The following is a description of a gene set: The dendritic cell (DC) is a master regulator of immune responses. Pathogenic viruses subvert normal immune function in DCs through the expression of immune antagonists. Understanding how these antagonists interact with the host immune system requires knowledge of the underlying genetic regulatory network that operates during an uninhibited antiviral response. In order to isolate and identify this network, we studied DCs infected with Newcastle Disease Virus (NDV), which is able to stimulate innate immunity and DC maturation through activation of RIG-I signaling, but lacks the ability to evade the human interferon response. To analyze this experimental model, we developed a new approach integrating genome-wide expression kinetics and time-dependent promoter analysis. We found that the genetic program underlying the antiviral cell state transition during the first 18-hours post-infection could be explained by a single regulatory network. Gene expression changes were driven by a step-wise multi-factor cascading control mechanism, where the specific transcription factors controlling expression changed over time. Within this network, most individual genes are regulated by multiple factors, indicating robustness against virus-encoded immune evasion genes. In addition to effectively recapitulating current biological knowledge, we predicted, and validated experimentally, antiviral roles for several novel transcription factors. More generally, our results show how a genetic program can be temporally controlled through a single regulatory network to achieve the large-scale genetic reprogramming characteristic of cell state transitions. Genes down-regulated in comparison of control conventional dendritic cells (cDC) at 0 h versus cDCs infected with Newcastle disease virus (NDV) at 10 h. Human Gene Set: GSE18791_CTRL_VS_NEWCASTLE_VIRUS_DC_10H_DN studied in species Homo sapiens from publication Zaslavsky E, Hershberg U, Seto J, Pham AM, Marquez S, Duke JL, Wetmur JG, Tenoever BR, Sealfon SC, Kleinstein SH (PMID 20164420), and this is the list of marker genes: STAT3, GPR180, CNP, NEMP1, IRF1, CXCL9, IFNA16, ADPRM, PI4K2B (NCBI Gene Id 55300), OAS2, TNFAIP3, INTS12, STAT2, DUSP5, MAML2, IFNA14, OAS3, ETV7, SBK1, BCL2, BCL2L14, TRIM5, ZBED1, RNF213, DTX3L, PLEKHA4, IDO1, IFNW1, USP42, TGM1, GBP4, CD80, PARP14, SAMD9L, SEZ6L2, MAP3K8, CMPK2, TMCC3, ACOT9, FAM107B, C1GALT1, DERL1, GTF2B (general transcription factor IIB), RIPOR2, SAMD9, PHACTR4, IFIT2, ISCA1, UBE2Z, ENTHD1, POM121L9P, ZC3H12C, MCUB, ARL5B, SPG11, CDC42EP3, FBXO34, ARAP2, SP140L, NPY4R, MASTL, TRIM22, LINC00658, ARHGEF11, STX11, IFNL1, SECTM1, PMAIP1, TRIM26, USP18, CARINH (colitis associated IRF1 antisense regulator of intestinal homeostasis), TMEM268, RNF144B, ATP10A, MKLN1, SHFL, PTGS2, NUDT17, CMTR1, ZNF267, SESN2, SNAPC1, DENND5A, SCNN1G, DYNLT1, RIPK2, IL6, DHX58, RTP4, ZBP1, RTCB, ISG15, SLFN13, DDX60, IFIT1, BET1, ARID5A, APOL1, PAG1 (phosphoprotein membrane anchor with glycosphingolipid microdomains 1), IFI44, CSRP2, IL15RA, APOBEC3G, GCH1, GPBP1, LINC01138, SLC9A3, EPSTI1, MX2, LYN, PNPT1, AIM2, APOL6, HERC6, PDGFRL (NCBI Gene Id 5157), TINAGL1, STARD5 (NCBI Gene Id 80765), DMXL1, IFIT3, FEM1C, SP140, SMCHD1, OTUD1, IFIH1, ADAR, OASL, IFNL2, ADAMTSL5, SLC31A2, GBP5, SFT2D2, ZNF579, ERO1A, BRIP1, NCOA7, DCP1A, TENT4A, ABTB2, CD274, TENT5A, FAS, CREM, SELENOI, NSUN3 (NCBI Gene Id 63899), PML, RNF138, SQOR, WARS1, ZNFX1, TNF, IRF8, PCGF5, SERPING1, CSRNP1, HMGN2P46, HERC5, NIPAL4, STX17, XAF1, FUT4, PHF11, IRF2, RAB9A, TRAF1, NAMPT, TNFSF10, PAPOLG, FAM135A, IFNA10, TNFSF15, CLK1, SLC1A6, TAP1, RIGI, PDE4B, ACTR10, NEXN, PPP4R1L (NCBI Gene Id 55370), IFIT5, TMEM140, AGAP2, PPP3CC, NLRC5, ANXA2R-AS1, C21orf91, GNA13, ARHGAP27, CDX2, PLSCR1, CYLD, DNAI1, TLK2, ITIH4, DRC3, TLR2, MXD1, BATF2, MIR155HG, PABIR3, IFNA8